Given this list of marker genes TFPI2, CHRDL1, PLA2G2A, ATP1A2, PPARG, ACACB, PPP1R1A, FZD4, CCL14, IFI44L, AKR1C3, GPD1, TAC1, SFRP1, GPX3, LPL, CES1, MEST, TNMD, PPP2R1B, CASQ2, CEBPA, SLC7A10, CTAG1B, SELENBP1, CD36, AKR1C1, GPC3, LMOD1, NPR1, IGF1, ACKR1, AOC3, APOD, IGKC, TIMP4, MTARC1, ITIH5, ABCC6, CETP, RBP4, G0S2, PCK1, LIPE, ABCA8, TMT1A, ADIRF, FABP4, ASPA, AGT, ADH1C, IGHG1, PLAAT3, FOSB, ADIPOQ, CFD, VIPR1, DUSP4, ANGPT1, GYG2, P3H2, SVEP1, AQP7, RAPGEF3, PLIN1, PDK4, FAM149A, SLC24A3, MAOA, IGLC2, IGHA1, C1orf115, NPY1R, ADH1B, CLEC3B, CA4, MAOB, SEMA3G, NTRK2, PTX3, PTGER3, BST2, ANGPTL4, CLDN5, PALMD, here is a description of the gene set: Human Gene Set: NAKAYAMA_SOFT_TISSUE_TUMORS_PCA2_DN species: Homo sapiens In soft tissue sarcomas, the diagnosis of malignant fibrous histiocytoma (MFH) has been a very controversial issue, and MFH is now considered to be reclassified into pleomorphic subtypes of other sarcomas. To characterize MFH genetically, we used an oligonucleotide microarray to analyze gene expression in 105 samples from 10 types of soft tissue tumors. Spindle cell and pleomorphic sarcomas, such as dedifferentiated liposarcoma, myxofibrosarcoma, leiomyosarcoma, malignant peripheral nerve sheath tumor (MPNST), fibrosarcoma and MFH, showed similar gene expression patterns compared to other tumors. Samples from those five sarcoma types could be classified into respective clusters based on gene expression by excluding MFH samples. We calculated distances between MFH samples and other five sarcoma types (dedifferentiated liposarcoma, myxofibrosarcoma, leiomyosarcoma, MPNST and fibrosarcoma) based on differentially expressed genes and evaluated similarities. Three of the 21 MFH samples showed marked similarities to one of the five sarcoma types, which were supported by histological findings. Although most of the remaining 18 MFH samples showed little or no histological resemblance to one of the five sarcoma types, 12 of them showed moderate similarities in terms of gene expression. These results explain the heterogeneity of MFH and show that the majority of MFHs could be reclassified into pleomorphic subtypes of other sarcomas. Taken together, gene expression profiling could be a useful tool to unveil the difference in the underlying molecular backgrounds, which leads to a rational taxonomy and diagnosis of a diverse group of soft tissue sarcomas. Top 100 probe sets contrubuting to the negative side of the 2nd principal component; associated with adipocytic differentiation. from publication Nakayama R, Nemoto T, Takahashi H, Ohta T, Kawai A, Seki K, Yoshida T, Toyama Y, Ichikawa H, Hasegawa T (PMID 17464315)